Given this list of marker genes CDK1, DRD5, RANBP2, HDAC2, FOSB (FosB proto-oncogene, AP-1 transcription factor subunit), EDNRA, COMT, DRD1, CPS1, ADAMTS13, DBH, PPP1R9B, PDE1B, SLC1A1, SOD1, ADORA2A, ASIC1, DRD4, PPP1R1B, GRIA1, RGS2, CALM3, KCNC2, HDAC6, ASS1, KCNC1, MYD88, NR4A2, HPRT1, RGS9, CD4, OXT, CAD, CNR2, UROS (uroporphyrinogen III synthase), GLDC, SLC18A2, DRD2, ITGA2, GNAL, EDN1, GRIN2A, PITX3, JAK2, RGS4, RRM2B, RGS17, here is a description of the gene set: Human Gene Set: GOBP_RESPONSE_TO_AMINE Any process that results in a change in state or activity of a cell or an organism (in terms of movement, secretion, enzyme production, gene expression, etc.) as a result of an amine stimulus. An amine is a compound formally derived from ammonia by replacing one, two or three hydrogen atoms by hydrocarbyl groups. species: Homo sapiens